Given this list of marker genes Foxj1, Tnfrsf14, Lgals9, Btla, Prnp, Havcr2, Casp3, Pawr, Arg2, Arg1, Cdkn2a, Scrib, Pten, Itch, Prkar1a, H2-T23, Zbtb7b, Lilrb4b, Scgb1a1, Gnrh1 (NCBI Gene Id 239161), Dlg5, Cd37, H2-M3, Rc3h1, Ihh, Pla2g2a, Zc3h12d, Pla2g2f, Vsig4, Shh, Cd86, Cd274, Gpnmb, Tsc2, Pla2g2d, Il4i1, Erbb2, Pla2g5, Marchf7, Bmp4, Ptpn6 (protein tyrosine phosphatase, non-receptor type 6), Lilrb4a, Tgfb1, Tnfrsf21, Ctla4, Laptm5, Il20rb, Ceacam1, Ido1, Pdcd1lg2, Vtcn1, Slc4a2, Sdc4, Mad1l1, Cebpb, Crtam, Peli1, Clec4g, Tarm1, Tspan32, Lrrc32, Pde5a (NCBI Gene Id 242202), Cblb, Il2ra (interleukin 2 receptor, alpha chain), Twsg1, Dlg1 (NCBI Gene Id 320792), Btn2a2, Slfn1, Cd44, Cd276, Cd24a, Xcl1, Ripor2, Ndfip1, Vsir (V-set immunoregulatory receptor), Tmem131l, Sftpd, Foxp3 (NCBI Gene Id 20371), Cd80, Spn, H2-Aa, Glmn, here is a description of the gene set: Any process that stops, prevents or reduces the rate or extent of T cell proliferation. species: Mus musculus Mouse Gene Set: GOBP_NEGATIVE_REGULATION_OF_T_CELL_PROLIFERATION